Given this list of marker genes BTNL9, SOD2-OT1, LINC00482, ADARB2, DHDH, LAIR1, RALGPS1, RPGRIP1, BCO2, MRC1, PDE8B, LINC01554, USP43, SPINK5, NR3C2 (nuclear receptor subfamily 3 group C member 2), JAKMIP2, A1BG, ADGRF5P2, DHRS9, BEST2, MUCL1, GRK4 (G protein-coupled receptor kinase 4), here is a description of the gene set: species: Homo sapiens Transcriptome of human HepaRG hepatocellular carcinoma liver progenitors in responses to a WNT3A-enriched microenvironment and dissection of pathways dependent on _-catenin and/or blocked by the SFRP-like Wnt inhibitor FZD8_CRD. from publication Mebarki S, Désert R, Sulpice L, Sicard M, Desille M, Canal F, Dubois-Pot Schneider H, Bergeat D, Turlin B, Bellaud P, Lavergne E, Le Guével R, Corlu A, Perret C, Coulouarn C, Clément B, Musso O (PMID 27191501) Human Gene Set: MEBARKI_HCC_PROGENITOR_WNT_DN_CTNNB1_DEPENDENT_BLOCKED_BY_FZD8CRD Methods: Liver progenitor cells were incubated in a WNT-enriched microenvironment for 72hrs (200 ng/ml mouse recombinant purified Wnt3A from R&D Systems). Gene pathways dependent on downstream _-catenin were studied by _-catenin knockdown with specific siRNA. Gene pathways blocked by extracellular SFRP-like Wnt inhibitors were studied by co-incubating cells with recombinant purified FZD8_CRD (300 ng/ml, from R&D Systems). Independent culture experiments performed in triplicate include untreated cells or cells incubated with scrambled siRNA or with _-catenin-specific siRNA or with FZD8_CRD, alone or in combination with Wnt3A.